The following is a description of a gene set: studied in species Homo sapiens Human Gene Set: HP_WIDE_CRANIAL_SUTURES An abnormally increased width of the cranial sutures for age-related norms (generally resulting from delayed closure). Wide cranial sutures, and this is the list of marker genes: MSX2, PEX1, ALDH18A1, RBM10, AGTR1, POLR3A, BANF1, AGT, VDR, CYP27B1, FIG4, REN, SEC24D, ZMPSTE24, GJA1, SLC34A3, LMNA, DCHS1, CYP2R1, ACE, VAC14 (VAC14 component of PIKFYVE complex), MMP2, TRPV6, CRTAP, FAT4, SETBP1, MED12, AGO2, ALPL